Given this list of marker genes GOT2, PXMP2, HOGA1, AGXT, SLC26A1, LDHA, DAO, GRHPR, HAO1, ALDH4A1, PRODH2, here is a description of the gene set: Human Gene Set: WP_GLYOXYLATE_METABOLISM Glyoxylate metabolism studied in species Homo sapiens